The following is a description of a gene set: species: Mus musculus Any process that modulates the frequency, rate or extent of addition of phosphate groups into a molecule. Mouse Gene Set: GOBP_REGULATION_OF_PHOSPHORYLATION, and this is the list of marker genes: Enpp1, Tnfrsf14, Slc11a1, Fzd4, Ptpn11, Lyn, Atxn1, Crkl, Tardbp, Smpd3, Araf, Ccnd1, Ropn1l, Irak1, Trim6, Itga5, Il9r (interleukin 9 receptor), Itga6, Tada2a, Ercc6, Csf2, Ppp2r5b, Ptpn5, Ighm, Snca, Cdc37, Ptpn13, Mcm7, Agt, Hnrnpu, Hes1, Sash1, Eef2k, Tnfsf18, Nup62, Kdr, Odam, Blvra, Gskip (NCBI Gene Id 66787), Cartpt, Map4k2, Itgb1bp1, Vldlr, Gadd45g, Myocd, Zc3h12a, Tesk1, Vtn, Ncam1, Sod1, Cd300a, Mapk9, Ralbp1, Lrp8, Prkca, Sirt1, Pbk, Irgm2, Dgkq, Prom2, Ppp1r15a, Prkcz, Sh2d1b2, Tnks1bp1, Grb10, Mprip, Ppp1r15b, Suz12, Pecam1, Tcl1, Cxcr4, Iqgap1, Dab2, Tnfrsf11a, Srpx2, Bmp2, Ncl, Tsg101, Cd4, Kitl, Drd1, Bdnf, Ankrd54, Nr2f2, Ppargc1b, Ptgis, Dusp10 (NCBI Gene Id 98270), Tnfrsf18, Pdgfra, Gsk3a, Kit, Cdkn2c (cyclin dependent kinase inhibitor 2C), Ptprj, Rasip1, Dscam, Cacul1, Adipor2, Zeb2, Strada, Mif, Snx9, Gfra2, Bcl10, Tpd52l1, Hras, Lrrk1, Aplp2, Crebl2, Bcl2, Pten, Dusp19, Rbl1 (NCBI Gene Id 99395), Ggnbp2, Cdk2ap1rt, Ralb, Bdkrb2, Pde5a, Fgd2, Fnip1, Cd74, Rgma, Gpr39, Dbndd2, Bak1, Kat2b, Ip6k2, Gfra1, Abl1, Sfrp1, Htt, Il24, P2ry1, Rassf2, Cox11, Map2k1, Adam9, Clec7a (NCBI Gene Id 56644), Ltf, Igf1, Fshr, Tspyl2, Ehd4 (EH-domain containing 4), Ptk2b, Nppa, Tlr8 (toll-like receptor 8), Reg3b, Cadm4, Tab1, Cln3, Rptor, Dhx34, Terf2ip, Traf6, Mapre3, Hgf, Dab1, App (NCBI Gene Id 319425), Ppia, Sqstm1, Hbb-bs, Tgfa, Fgfr1, Rasgrp1, Cripto, Slc8a2, Fnip2, Ppp5c (NCBI Gene Id 19060), Traf4, Phip, Pxn, Ilk, Hax1, Heg1, Adam17, Midn (midnolin), Rap2a, Sema4d, Rap2b, Traf3ip1 (TRAF3 interacting protein 1), Txn1, Mapkap1, Lrp6, Map3k11, Prkag2, Fgf1, Nras, Ang4, Map2k6, Pard6a, Itgb2, Apoe, Irs2, Adcyap1, Fgf18, Eif2ak3, L1cam, Ntrk1, Igfbp3, Slc8a3 (NCBI Gene Id 20543), Prkrip1, Thbs1, Lilra5, Fech, Niban1, Firrm, Park7, P2rx7, Stox1, Apc, Irs1, Kirrel1, Taok3 (NCBI Gene Id 72857), Trib2, Gbp4, Tlr4 (toll-like receptor 4), Thpo, S1pr2, Sfrp2, Dynll1, Nbn, Chordc1, Sh3bp5, Cdk5rap1, Il15, Adra2b, Mvp, Adcy8, Fgf15, Faxdc2, Emp2, Tlr7, Il21, Adrb2, Erbb2, Cryaa, Eif2ak4, Ep300, Cep43, Abi1, Mmd, Fzd8, Spdya, Sphk1, Pdcd10, Mllt1, Ang6, Ptk2, Insr, Pik3r6, Hes5, Fcer1a, Sh3gl2, Plec, Stat2 (NCBI Gene Id 80602), Pkib, Ogt, Tsacc, Ibtk, Lilrb4a, Adnp, Arhgef5 (Rho guanine nucleotide exchange factor 5), Anxa2, Il22ra2, Dstyk, Zzef1, Wnk4, Fn1, Trf (transferrin), Brat1, Zfp592, Rgcc, Cnot9, Fgf2, Fbn1, Pin1, Inca1, Socs5, Ikbkb, Rapgef3, Cep85, Il5, Tspan9, Eef1a2, Mt3, Rbl2, Fzd7, Ccl5, Gstp-ps, Mst1, Il23a, Smad7, Adtrp, Axin1, Yes1, Gstp2, Pink1, Xdh, Atf2, Zfp91, Ptger3, Stk4, Pdcd4, Oprd1, Rap1a, Ccl19, Gper1, Hipk2, Aida, Cd109, Cx3cl1, Tlr6, Bst1, Cdkn2d, Cops8, Arl2bp, Ctdsp1, Prox1, Ubash3b, Adar, Ksr1, Fbxw7, Dlg1, Ccl19-ps5, Il11, Eng, Tenm1, Fam20a, Raf1, Ccny (NCBI Gene Id 75537), Samsn1, Cenpe, Jak2, Sptbn4, Dvl2, Cdk5r2, Akap6, Ccl19-ps1, Crlf1, Cdk5rap3, Cnot7 (CCR4-NOT transcription complex, subunit 7), Nox4, Lrrn3, Grk2, Aplnr, Mlst8, Xbp1, Tnfaip3, Ripk3, Nos1, Cav1, Ptger4, Robo1, Dvl3, Chi3l1, Cemip, Nedd9, Inpp5j, Dok7, Tpx2, Il3, Ube2k, Il6ra, Grk3, Hnf1a, Irf1, Braf, Cactin, Bax, Tlr1 (toll-like receptor 1), Ret, Socs1, Syap1, Gckr, Nck1, Qars1, Fgf10, Bmp6, Prkd1, Zbed3, Itgb1, Hspa4, Tbx1, Ctdsp2, Ccdc88a, Thbs4, Mob1b, Epha7, Hhex, Fbh1, Akap5, Thy1 (NCBI Gene Id 21838), Htr2b, Ntrk2, Phactr1, Lrrk2, Sez6l2, Spry4, Hsp90aa1, Lmo4, Pip5kl1, Ajuba, Itgb2l, Hspa2, Hdac6, Chga, Efna5, Grk1, Pin1rt1, Spink1, Ripk2, Cck, Tlr9, Trem2, Rasa1, Spry1, Rit2, Ccnyl1, Stil, Rhoa, F2, Cib1, Smg8, Tm9sf5, Prkn, Pik3r1, Pfn2, Lep, Pparg, Nkx3-1, Impact, Slamf8, Clcf1 (cardiotrophin-like cytokine factor 1), Map2k3, Tnf, Il7, Rgn, Wnt1, Ins2, Gnaq, Ang5, Dusp3, Cspg4, Sez6, Isl1, Osm, Plxnb2, Cd3e, Fer, Xrcc6, Pik3cg, Map3k13, Xrcc5, Apln, Gadd45b (NCBI Gene Id 17873), Ptpro (protein tyrosine phosphatase receptor type O), Ifng, Fem1a, Fgfr3, Blm, Ocln, Prkar1a, Eif4g1, Egfr, Cadm1, Pycard, Grem1, Zgpat, Csf3, Vangl2, Gpnmb, Spred2, Arr3, Spred1, Rad50, Camp, Il4, Angpt1, Atxn7, Il12b, Hrc, Ptprt, Pax6, Slit2, Itpkb, Mas1, Bmp4, Ulk4, Irak3, Epm2a, Ednra, Edn1, Acp4, Rtraf, Kndc1, Prkdc, Mrnip (NCBI Gene Id 72859), Nsd1, Psrc1, Large1, Stk11, Stk38 (NCBI Gene Id 77222), Vegfb, Gata1, Ddx3x, Gadd45a, Fgr, Ezh2, Prkaa1 (NCBI Gene Id 105952), Trpc5, Slco3a1, Egf, Lox, Epo, Map2k4, Bag1, Pim1, Tnfsf11, Sez6l, Dusp6, Inpp5f (inositol polyphosphate-5-phosphatase F), Cd44, Nolc1, Spdye4a, Zfp622, Ccn2, Spn, Musk, Rps3, Itgb3, Hgs, Neurl1a, Mir26a-2, Lilrb4b, Osbp, Gsk3b, Mad2l2, Lck, Il1b, Crh, Fmr1, Ndufs4, Csf1r, Prr5l, Daxx (NCBI Gene Id 13163), Cdkn1a, Cimap3, Ptpn22, Ttc36, Rb1cc1, Pde4d, Flt4, Tfap4, Vegfa, Ptprc, Ccl19-ps6, Ptprh, Lif, Ar, Il18, Fzd5, Adarb1, Fbln1, Bard1, Fas, Parp14, Wnk3 (WNK lysine deficient protein kinase 3), Sh2d1b1, Erbb4, Pid1, Agap2, Rac1, Wars1, Mre11a, Bag4, Prkcd, Hdac3, Akt1, Cnksr3, Met, Tcim, Atg14, Jun, Wnt3a, Higd1a, Mmp9, Ldb2, Tgfb1, Psen1, Tigar, Ropn1, Ldb1, Bcar3, Wdr59, Fkbp8, Nhlrc1, Hbegf, Pdgfd, Pih1d1, Cntn1, Pdgfc, Trim65, Tnfrsf4, Cldn19, Arrb2, Erp29, Abi2, Il22, Fzd1, Stap1, Hrg, Cdkn1b, Cdkn2a, Mmd2, Pdgfb (NCBI Gene Id 18591), Gprc5b, Gck, Drd4, Gtpbp4, Pibf1, Smo, Ankle2 (NCBI Gene Id 71782), Lepr, Agrn, Glmn, Hmga2, Flot1, Coro1c, Wnt5a, Synpo2 (synaptopodin 2), Flt3l, Edn3, Deptor, Bmpr2, Gstp3, Fgf4, Hmgb1, Gba1, Mir26a-1, Dynap, Sesn2 (sestrin 2), Sfn, Rap2c, Ccnd2, Cd40, Akap9, Lrp4, Map3k7, Wnt9b (NCBI Gene Id 22412), Insm1, Cntf, Mapk8ip3, Igtp, Il2, Ptprz1, Tsc2, Ect2, Slc8a1, Nprl2, Map3k12, Mapk8ip1 (mitogen-activated protein kinase 8 interacting protein 1), Dab2ip, Wwtr1, Spag9, Errfi1, Ptges3, Ang, Nrg1, Pla2g6, Cdk12, Mavs, Gpd1l, Pik3ca, Gnas, Tab2 (TGF-beta activated kinase 1/MAP3K7 binding protein 2), Eif2ak1, Prlr, Kctd20, Arhgef2, Hnf4a, Il6st, Lats1, Prdx3, Shb, Fbxo7, Dnajc3, Nrbf2, Tirap, Nrxn1, Fgf8 (NCBI Gene Id 14179), Sox9, Maged1, Htr2a, Rspo1, Birc3, Ntf3, Dkk1, Drd2, Trim27, Uvrag, Dusp22, Areg, Fgf7, Ccn1, Ednrb, Nherf1, Lime1, Cav2, Magi3, Uchl1, Chmp6, Inhba, Ddrgk1, Tead1, Ppp4c, C3, Card14, Rock2, Map3k10, Cav3, Aktip, Clip3, Mcph1, C1qtnf9, Phlpp1, Sema7a, Socs4, Ccnb1, Tmem102, Dock7, Ntrk3 (neurotrophic tyrosine kinase, receptor, type 3), Ppp1r9b, Sdcbp, Nlrc5, Cblc, Apoa1, Chrna3, Men1, Ppp2r5d, Hus1, Pdgfrb, Inpp5k, Camk1, Ppm1f, Ppef2, Adra2a, Dusp1, Adra2c, Ppp2r3c, Zfp418, Psen2, Bccip, Plaur, Avp, Nod2, Pak2, Pkn1, Hyal2, C9orf72, Clspn, Epha4 (Eph receptor A4), Src, Csf1, Flt3, Nek10, Dusp7, Angpt4, Ppm1e, Ccl19-ps4 (C-C motif chemokine ligand 19, pseudogene 4), Hsf1, Rad51, Gprc5a, Hdac2, Tek, Spatc1l, Ngf, Reln, Jtb, Tsc1, Iqgap3, Mir26b, Ptpn2, Cd6, Tnk2, Gdnf, Pard3, Kdm4d, Ifnb1, Parp9, Rad17, Ager, Hpx, Dynapl1, Slc1a1, Il34, Map3k1, Fabp4, Sirt2, Hmgcr, Traf2, Cass4, Mstn, Ereg, Rarres2, Akt2, Socs3, 2610042L04Rik, Slfn1, Cdk5, Rictor, Ang2, Mtor, Spry2, Dtnbp1, Cdon, Fyn, Ppp2ca, Pik3r3, Hcls1, Nckap1l, Garem1, Peli2, Wdr24, Rgs14, Card10, Ddr2, Nop53, Dnaja1, Bdkrb1, Gstp1, Rps23rg1, Tom1l1, Ern1, Ceacam1, Il13, Ttbk1, Nf2, Kif14, Fndc1, Enpp2, Fgd4, Pik3r5, Dmtn, Rapgef2, Rack1, Mydgf, Cdh5, Ctdspl, Tgfb2, Macroh2a1, Ern2, Chrna7, Aif1, Trib3 (NCBI Gene Id 23913), Csnk1d, Ucn, Bmp7, Cx3cr1 (NCBI Gene Id 13051), D1Pas1, Ptpn6 (protein tyrosine phosphatase, non-receptor type 6), Map3k5, Klhl31, Cd80, Flt1, Npm1, Prnp, Ripk1, Nf1, Il12a, Syk, Rgs2, Ppargc1a, Hspb1, Gab1, Cdk2ap1, Trib1, Dnaja3, Prkce, Hexim2, Dnajc10, Casp3, Il31ra, Mapt, Tada3, Ccr7, Ccl19-ps3, Irgm1, Ifnar1, Akap11, Il9, Zfyve28, Notch2, Psmd10, Trpt1, Tfrc, Celsr3, Pkia, Dvl1, Mob2, Trpc6, Akt1s1, Gjc2, Epha1, Acvr2a, Lonp1, Reg1, Cdkn2b, Ins1, Tmed2, Chp1, Cd24a, Pdgfa, Vps25, Rb1, Plpp3, Etaa1, Eif4g3, Paqr3, Kirrel2, Mst1r, Cab39, Cldn3, Icam1, Tnfrsf1a (NCBI Gene Id 21937), Map2k2, Wee2, Tnik, Plk1, Lats2, Axin2, Map3k4, Il6, Arrb1, Hipk3, Limk2, Ptpn1, Ptprb, Rabgef1, Ctf1, Cdc25b, Abi3, Ctnnd1 (catenin delta 1), Chek2, Fiz1, Wdfy2, Adipoq, Nrp1, Mapk15, Stradb, Ccnd3, Cdkn1c, Ptk6, Ptges3-ps, Camkk2, Mapk1, Unc119, Kras, Taf7, Mlxipl, Gas6, Bank1, Smyd3, Sfrp5, Efna1 (ephrin A1), Pebp1, Myadm, Vegfc, Pak1, Srcin1, Nptn, Pkig, Limch1 (LIM and calponin homology domains 1), Smpd1, Cdk5r1, Map2k7, Senp2, Nnt, Prr5, Itln1, Als2, Prkch, Nlrp12, Adcy10, Pdcl3, Acvr1